The following is a description of a gene set: Any process in which endoplasmic reticulum is transported to, and/or maintained in, a specific location within the cell. species: Mus musculus Mouse Gene Set: GOBP_ENDOPLASMIC_RETICULUM_LOCALIZATION, and this is the list of marker genes: Zbed3, Esyt1, Esyt2, Polr2m, Gramd2a, Tle6, Myo5a, Vapa, Vapb, Esyt3